The following is a description of a gene set: Mouse Gene Set: GOBP_PROTEIN_LOCALIZATION_TO_CILIUM A process in which a protein is transported to, or maintained in, a location within a cilium. species: Mus musculus, and this is the list of marker genes: Rom1, Cfap53, Ift140, Arf4, Bbip1, Arl3, Tulp3, Wdr35, Asap1, Ccdc40, Ccdc39, Tulp2, Arl6 (NCBI Gene Id 80660), Ttc21b, Cfap58, Dzip1, Bbs9, Lztfl1, Wdr19, Spata7, Invs, Tbc1d32, Arl13a, Cplane1, Rab8a (NCBI Gene Id 17274), Dync2h1, Ccdc88a, Ttc21a (NCBI Gene Id 74052), Ift56, Cc2d2b, Ccdc66, Bbs1, Fsip2, Gfy, Fam149b, Atp6v1d, Snx10, Tctn2, Csnk1d, Gsk3b, Tctn1, Pcare, Dnaaf11, Dzip1l, Inpp5e, Ehd1, Mapk15, Gga1, Iqce, Efcab7, Crocc, Arl13b, Ift122, Ropn1, Rabep1, Tub, Rab11a, Entr1 (NCBI Gene Id 78707), Odad4, Bbs4, Rab29, Rab3ip, Cep78, Gas8, Tmem107, Nphp4, Tulp1, Micall1, Ift80, Rab11fip3, Cdk20, Cc2d2a, Gdi2, Zdhhc3, Ift20, Zmynd10, Zfp423